Given this list of marker genes PXMP2, RPL10L, PRKCD, TAX1BP1, DCLRE1C, EID1, MYLIP, RPS14, ENSG00000275616, CCN3, LUZP1, CD59, DCTN3, COX5B, CHN2, ZNF91, THY1, PNPLA4, IFNA10, KLRF1, PITX1-AS1, RAB4A, COX11, POLR2I, CHMP4A, MRPL23, NUDT3, RPL36, RPL15P22, RYBP, LSM7, UROD, RPL28, PHB1, APOE, ARIH2, PQBP1, RBBP6, HADHA, DNAJA4, MAPK1, here is a description of the gene set: Genes down-regulated in myeloid progenitor cells isolated from bone marrow of patients with Diamond-Blackfan anemia (DBA) and mutated RPS19. Diamond-Blackfan anemia (DBA) is a broad developmental disease characterized by anemia, bone marrow (BM) erythroblastopenia, and an increased incidence of malignancy. Mutations in ribosomal protein gene S19 (RPS19) are found in approximately 25% of DBA patients; however, the role of RPS19 in the pathogenesis of DBA remains unknown. Using global gene expression analysis, we compared highly purified multipotential, erythroid, and myeloid BM progenitors from RPS19 mutated and control individuals. We found several ribosomal protein genes downregulated in all DBA progenitors. Apoptosis genes, such as TNFRSF10B and FAS, transcriptional control genes, including the erythropoietic transcription factor MYB (encoding c-myb), and translational genes were greatly dysregulated, mostly in diseased erythroid cells. Cancer-related genes, including RAS family oncogenes and tumor suppressor genes, were significantly dysregulated in all diseased progenitors. In addition, our results provide evidence that RPS19 mutations lead to codownregulation of multiple ribosomal protein genes, as well as downregulation of genes involved in translation in DBA cells. In conclusion, the altered expression of cancer-related genes suggests a molecular basis for malignancy in DBA. Downregulation of c-myb expression, which causes complete failure of fetal liver erythropoiesis in knockout mice, suggests a link between RPS19 mutations and reduced erythropoiesis in DBA. Human Gene Set: GAZDA_DIAMOND_BLACKFAN_ANEMIA_MYELOID_DN species: Homo sapiens from publication Gazda HT, Kho AT, Sanoudou D, Zaucha JM, Kohane IS, Sieff CA, Beggs AH (PMID 16741228)